The following is a description of a gene set: from publication Yevshin I, Sharipov R, Kolmykov S, Kondrakhin Y, Kolpakov F (PMID 30445619) Genes containing one or more binding sites for (ZNF585B) in their promoter regions (TSS -1000,+100 bp) as identified by GTRD version 20.06 ChIP-seq harmonization. Human Gene Set: ZNF585B_TARGET_GENES studied in species Homo sapiens, and this is the list of marker genes: LINC00431, ZNF546, CHMP1A, PIGN, KDM8, BCR, PDPN, ORMDL1, DNAI4, SERINC1 (NCBI Gene Id 57515), DDHD1, CPD, SLC2A1-DT, HMBOX1, USP32, TSKU, PLPP5, RELCH, LRRC34 (NCBI Gene Id 151827), QRICH1, DIAPH1, LINC02769, OAT, PPP2R5C, CFAP36, MCMBP, MVP, GRASLND, IP6K1, SQSTM1, ZNF45, ANK2, HES1, RFTN1, ZCRB1, HOXD10, CCDC9, RPL36P5, MAFB (NCBI Gene Id 9935), CCDC66, RNASEH2C (NCBI Gene Id 84153), CYP4V2, ZBTB22, ATP6V0A1, CYRIB, MGAT4B, CNDP1, ZNF529, ZNF529-AS1, ZNF57 (zinc finger protein 57), SIRT2, PMS1, ZNF503-AS2, MED12, RNF186-AS1, SMC6, SUMO2P8, PRXL2C (peroxiredoxin like 2C), TBC1D30, ZNF540, MSL3, LURAP1, NAGA, LINC02934, PEG13, FOXN3, IPO9-AS1, RNF24, RNU6-1228P, ATP6V1C1, MN1, MVP-DT, LINC01931, SESN3, STRADA, RUFY3, LINC02930, SLC2A1, PRKG1, TAGAP-AS1, ERCC2, MEGF10, PHIP, GPR137, CERCAM, MPHOSPH10P1 (MPHOSPH10 pseudogene 1), LINC03021, RPS10P27, TXLNA, NPR3, KDM4C, ENSG00000260288, PAK3, MIR1273C, LINC01852, MCPH1, TMEM131, SCARB1 (NCBI Gene Id 949), LNCRNA-IUR, DTD2, CLK2, TM7SF3, LOXL1, P3H3, ZFHX4, CATSPERB, ZNF551, NECTIN1, TMCC2, ETNK1-DT, SGIP1, CEP295, RNU5A-8P, ENSG00000235979, CALM1, ACSL3, ETNPPL, PPHLN1, LINC00926, INO80D-AS1, PRSS12, KANSL2, PHF3, PTPN7, RBFOX3, FKBP5, NUB1, SPATA33, TPT1P15, RPL21P77, LOXL1-AS1, ARRB1, TCF25, CCDC178, TIMM44, RAI14, ZNF778, RNU6-784P, RPL11P4